The following is a description of a gene set: Mouse Gene Set: GOBP_NEGATIVE_REGULATION_OF_LEUKOCYTE_PROLIFERATION Any process that stops, prevents, or reduces the frequency, rate or extent of leukocyte proliferation. species: Mus musculus, and this is the list of marker genes: Lilrb4b, Foxp3, Clec4g (C-type lectin domain family 4, member g), Cdkn2a, Lrrc32, Vsig4, Ripor2, Pawr, Gnrh1, Ptpn6, Slfn1, Spn, Foxj1, Grem1, Btk, Slc4a2, Gpnmb, Ccl12, Laptm5, Prnp, Pla2g2a, Dlg1, Rc3h1, Sox11, Il2ra (interleukin 2 receptor, alpha chain), Casp3, Xcl1, Dlg5, Lyn, Cd300a, Nf1, Vsir, H2-T23, Pdcd1lg2, Cd86, Cd274, Tsc2, Cblb, H2-Aa, Bcl6, Rassf5, Tmem131l, Peli1, Pkn1, Pde5a, Sftpd, Cd276, Tarm1, Tgfb1, Itch, Zc3h12d, Il33 (NCBI Gene Id 77125), Gstp1, Gal, Erbb2, Zbtb7b, Il10, Tnfrsf13b, Btn2a2, Glmn, Twsg1, Cd37, Pten, Lgals9, Shh, Arg1, Ceacam1, Cebpb, Inpp5d, H2-M3, Fcgr2b, Mad1l1, Pla2g5, Vtcn1, Il2 (NCBI Gene Id 16183), Il4i1, Lst1, Cd80, Pla2g2d, Il20rb, Bmp4, Ndfip1, Btla, Crtam, Ido1, Atm, Ctla4, Ihh, Tnfrsf21, Cd44, Arg2, Pla2g2f, Havcr2, Tyrobp, Tnfrsf14, Marchf7, Scgb1a1, Phf7, Cd24a, Scrib, Sdc4, Tspan32, Prkar1a, Crp, Enpp3, Lilrb4a